The following is a description of a gene set: Human Gene Set: HP_FAT_MALABSORPTION Fat malabsorption species: Homo sapiens Abnormality of the absorption of fat from the gastrointestinal tract., and this is the list of marker genes: LBR, SERPINA1, AMACR, PTF1A, CCDC47, CLCA4, DCTN4, PNLIP, MTTP, SLC11A1, ACOX2, CLMP, MMEL1, SHPK, TNPO3, HSD3B7, SLC26A9, CEACAM3, PMM2, HMOX1, HLA-DQB1, SRP54, TGFB1, PRSS1, CTRC, PEX12, GSTM3, KCNN4, ANTXR2, IRF5, STX1A (syntaxin 1A), PERCC1, COX4I2, MIF, PRSS2, DNAJC21, EPCAM, DZIP1L, MPI, FCGR2A, AKR1D1, PKHD1, SLC7A7, HFE, HMGCS2, TJP2, SLC9A3, ABCB11, POU2AF1, EDNRA, CFTR, GCLC, ATP8B1, EFL1, IL12A, IL12RB1, SPINK1, SLC6A14, APOB, SBDS, PTRH2, CEACAM6, TNFSF15, SPIB, SAR1B, SLC51B, HLA-DQA1, SLC10A2, LIPA, CYP7B1